Given this list of marker genes KCTD1, C1R, RAB23, OFD1, LRP6, UBR1, RIPK4, EP300, DVL3, WNT10A, RECQL4, NSD1, CREBBP, SATB2, PIGA, WDR35, TFAP2B, RAD51, MSX1, MESD, APC2, GNB2, C1S, here is a description of the gene set: A congenital defect characterized by the absence of one or more permanent teeth, including oligodontia, hypodontia, and adontia of the of permanent teeth. Agenesis of permanent teeth species: Homo sapiens Human Gene Set: HP_AGENESIS_OF_PERMANENT_TEETH